Given this list of marker genes AVL9, HACD3, C7orf50, TMX4, AP3S1, P2RY13, ALDH5A1, TNRC6B, TMEM170B, ZC3H6, EIF4EBP1, STS, EVI5, TNFRSF21, ZFHX3, ARHGDIB, FBLIM1, RHOB, CDK19, SPATA12, COQ4, DUSP28, TRIM52, PRORP, B3GNT2, SKAP2, CLN6, MSH2, DYRK4, PLA2G15, SKIC8, TMEM223, MTMR10, BAIAP2-DT, PPM1M, HTT, PARVG, MMD, TCEAL1, MGAT4B, TRAM2, ZNF14, QKI (NCBI Gene Id 9444), RBL2, SYNJ2BP, EXOC4, ATP6V0A1, RAB4A, PMS1, SMARCC1, C8orf33, WNK1, NDUFC2, AMDHD1, ZNF567, ATP6V0E2, MRTFB, NMNAT1, GCLC, TP53INP1, ME3, APBA1, MTMR12 (NCBI Gene Id 54545), PTGFRN (prostaglandin F2 receptor inhibitor), FGD4, APMAP, CD22, AP1B1 (NCBI Gene Id 162), SLC39A10, HACD2, TIMMDC1, ANKRD6, EHMT2, GRN, ANAPC15, GDE1, RIN3, TRAPPC10, PLBD2, NBPF10 (NBPF member 10), LRMDA, SEC14L1, EPAS1, PTPN18 (protein tyrosine phosphatase non-receptor type 18), ZBTB41, ATP6V1D, PMFBP1, PLCB2, COMTD1, TPCN1, HEXA, CNOT6L (CCR4-NOT transcription complex subunit 6 like), IARS2, GANC, MAP4K3, PXMP4, FCGRT, DIPK2A, PEPD, EPB41L2, KPNA3, ATM, KCTD18, GPRIN3, C16orf54, TXNDC12, VPS41, NUFIP2, POGK, MYCBP2, OMA1, ZBTB18, CLIP4, STX10 (NCBI Gene Id 8677), PCM1, SCCPDH, CLN3, RPUSD2, FN3KRP, RAP2B, TUFM, AVPI1, NLRC4, PLEKHA8, PAK1, TMEM9B, RPN1, RNF125, GPAM, ERCC5, MAP1S, FOXRED2, ADORA3, PLBD1, C11orf21, IQGAP2, QSER1, ANKRD34C, SWAP70, ACBD5, ATRN (attractin), ZNF496, FAR1, CDC40, RNF141, ETFRF1, RNF113A, SLC2A9, ITM2B, GHDC, GLB1, TSPAN11, PDK3, ZNF197, MXI1, COQ8A, ZNF702P, RNF181, RNASET2, ABHD14A, KCNE3, DTWD1, NPL, CD302 (NCBI Gene Id 9936), PAQR8, PEMT, DYRK2, DENND4C, RTL10, SNAI3 (NCBI Gene Id 333929), TMEM37, COX11 (cytochrome c oxidase copper chaperone COX11), ZNF302, CHPT1, HDHD5, CCPG1, PCYOX1, COMMD3, NDUFB10, CBX1, LAMP2, ZKSCAN4, TM7SF3, CORO2A, ERP29, OSGEP, HADH, PDE7A, SLC35A1, DOK2, ANP32A, CCDC88A, PLXDC2, MEGF9, HDLBP, KIAA2013, PHYH, GATM, ZNF252P, here is a description of the gene set: studied in species Homo sapiens Human Gene Set: GSE9960_GRAM_NEG_VS_GRAM_POS_SEPSIS_PBMC_DN To identify signature genes that help distinguish (1) sepsis from non-infectious causes of systemic inflammatory response syndrome, (2) between Gram-positive and Gram-negative sepsis. from publication Payen D, Lukaszewicz AC (PMID 19535937) Genes down-regulated in peripheral blood monocytes (PMBC): Gram negative sepsis versus Gram positive sepsis.